The following is a description of a gene set: Human Gene Set: GOBP_DNA_TEMPLATED_TRANSCRIPTION_TERMINATION The completion of transcription: the RNA polymerase pauses, the RNA-DNA hybrid dissociates, followed by the release of the RNA polymerase from its DNA template. species: Homo sapiens, and this is the list of marker genes: SSU72L3, PRMT5 (protein arginine methyltransferase 5), ZMPSTE24, XRN2, TTF1, WNK1, PPP1R10, TTF2, POLR2A, SMN1, SSU72L5, ZC3H4, PPP1CA, SSU72L2, SSU72L1, PCF11 (PCF11 cleavage and polyadenylation factor subunit), SSU72L4, POLR1H, SETX, MTERF1, MAZ, WDR82, DHX9, SSU72L6, MTERF2, SSU72, SMN2, SCAF4, CAVIN1, SCAF8